Given this list of marker genes LPIN1, CFHR3, CLCNKA, SLC22A12, ALDOA, PIGA, STAT2, CFB, LDHA, PKHD1, CFI, FLT1, CACNA1S, SLC26A1, TCN2, HNF1B, CFH, PYGM, MT-CO1, SEC61A1, APRT, HELLPAR, THBD, CCND1, SLC2A9, IFT140, OBSCN, CLCNKB, SAA1, MT-CO3, STOX1, PRPS1, CFHR1, PRDX1, DGKE, RYR1, EBF3, BSND, C3, CORIN, HPRT1, DZIP1L, MMACHC, CD46, here is a description of the gene set: Acute kidney injury Human Gene Set: HP_ACUTE_KIDNEY_INJURY studied in species Homo sapiens Sudden loss of renal function, as manifested by decreased urine production, and a rise in serum creatinine or blood urea nitrogen concentration (azotemia).